The following is a description of a gene set: Pattern of blood flow in the heart that deviates from the normal circuit of the circulatory system. species: Homo sapiens Cardiac shunt Human Gene Set: HP_CARDIAC_SHUNT, and this is the list of marker genes: TLL1, CITED2, ACTC1, GATA4 (GATA binding protein 4), MYH6, ACVRL1, THOC6, DBR1, GATA6, IFT56, FOXF1, NKX2-5, TBX20, MYH11, ENG